The following is a description of a gene set: species: Mus musculus Mouse Gene Set: GOCC_SYNAPSE_ASSOCIATED_EXTRACELLULAR_MATRIX The extracellular matrix of the perisynaptic space (the extracellular space adjacent to the synapse) and the synaptic cleft., and this is the list of marker genes: Vcan, Hapln1, Sparcl1, Tnr, Lama5, Tnc, Ptprz1, Hapln2, Ncan, Hapln3, Hapln4, Acan, Bcan